The following is a description of a gene set: studied in species Mus musculus Mouse Gene Set: GOBP_REGULATION_OF_CILIUM_MOVEMENT Any process that modulates the rate, frequency, or extent of cilium movement, the directed, self-propelled movement of a cilium., and this is the list of marker genes: Wfdc6b, Ccdc39, Ccdc40, Dnah11, Bbs1, Cfap206, Rnase10, Tacr1, Defb37, Ttll6, Cfap298, Irgc, Drc1, Adam7, Kif9, Anxa5, Clxn, Or4m1, Spag6l, Gas2l2, Wfdc6a, Dnaaf1, Iqcf1, Catsper1, Tac1, Cfap43, Rsph4a, Cfap69, Tacr2, Cfap20, Eppin, Cyb5d1, Rnase9, Ccdc65 (NCBI Gene Id 223882), Tac2, Tac4, Tex101, Rgn, Odad2 (NCBI Gene Id 74934), Defb1, Spinkl, Mkks, Tacr3, Cfap45 (NCBI Gene Id 71870), Tppp2, Bbs4, Ccr6, Prdm14, Bbs2